Given this list of marker genes Psg27, Musk, Slamf7, Klrc1, Ada, Itga5, Prss8, Ly6g, Cd200r3, Pdcd1lg2, Tnfrsf22, Ackr4, Il11ra1, Dnai2, Fcgrt, Gp2, Itga2b, Cd274, Cd27, Btnl4, Mr1, Cd48, Gypa, Ermap (NCBI Gene Id 99987), Dag1, Scnn1b, Cd4, Raet1e, Chrna4, Ly6g6d, H2-M9, Il21r, Tnfrsf13c, Clec2h, Cd8b1, Skint1, Enpp3, Csf2rb, H2-Eb1, Fcrl5, S1pr1, Adam20, Hfe, Bmpr1a, Clec4d, Asgr2, Tmem123, Ace, Itgal (integrin alpha L), Ccr7, Plau, Ccr6, Cxcr1, Ackr3, Ctla4, Trgc2, Ptprc, Cd33, Asgr1, F2 (coagulation factor II), Ncam1, Ceacam12, Ctsl, Cd276, Skint11, Gfra1, Mpl, Ide, Itga3, H2-T15, Vpreb1a, Trpv1 (transient receptor potential cation channel, subfamily V, member 1), Fgb, Pdcd1, Kit, H2-T13, Tnfsf13, Clec4f, Muc17, Tas2r118 (NCBI Gene Id 387347), Folr1, Il1r1, Btnl1, Ly6c1, Clec10a, Cxcl12, Ccr2 (C-C motif chemokine receptor 2), Abca1 (ATP-binding cassette, sub-family A member 1), Ceacam13, Trdc, Btnl9, P4hb, Crlf2, Ano1, H60c, Vsir, Ly6g5b, Ccr1, Rtn4r, Trpm8, Clec7a, P2rx7, Itga4, Tnfrsf18, Tnfrsf4, Krt18, Ccr1l1, Clec2i, Trgc1, Cfh, Plg, Cd3e, Scube1, Il7r, Adam39, Thbs1, Il4, Itgax, Flt3, Cd83, Klrd1, Ccr5, Cd209c, Siglece, Ctsk, H60b, Il9r, Ccrl2, Gpc4, Fcer2a, Scnn1a, Adam1a, Cd163, Itgb3, Heg1, Htr2c, Icosl, Cd24a, H2-M1, Ece1, Art2b, Tcn2, Ighm, Cd84, Nt5e, Adam6b, Adam34, Map3k5, Cd200r1, Ackr2, Klri1, H2-K1, H2-Aa, Hyal5, Abcb1b, H2-Q1, Ccr4, Itga10, Itgb1, Cd74, Crlf1, Clptm1, Spam1, Cd59b, Enox1, Cxcr5, Adam1b, Trgv2, Ulbp1, Ighd, Car4, 2410137M14Rik, Alpi, Glrb, Skint4 (NCBI Gene Id 320640), Psg25, Fcrl2, Il13ra2, Spa17, Abcc4, Antxr1, Art2a, Clec4a4, Cd86, Slc1a1, Tfrc, Ngfr, Ctsb, Plppr4, Sema7a, Psg26, Lepr, Sell, Fcgr2b (NCBI Gene Id 98391), H2-M5, Abcg2, Il2rg, Mill2, H2-M2, H2-M10.4, Klra4, H2-Q6 (NCBI Gene Id 636948), Vtcn1, Osmr, H2-D1, Klrc2, Gm4787, Cd248, Eng, Tnfrsf14, Tlr8, Itga1, Nlgn1, Astn1, Cd200r2, Itga9, Trgv3, Btn1a1, Chrnb2, Gfra3, Azgp1, Itgam, Itga2, Adam29, H2-M11 (NCBI Gene Id 224754), B4galt1, Skint3, Cxcl10, Gp1ba, Ceacam3, Sele, Robo4, Ccr3, Clec2f, Cxcr6, Anxa5, Lrp2, Cd9, Skint10, Ly6g6c, Btnl2, Adam19, Atp1b2, Kcnj3, Cd44, Mfge8, Plaur, Skint9, H2-T24, Folr2, Adam26a, Vcam1, Rtn4rl2, Cntfr, Cd209a, Clec12b, Adgra3, Slamf6, Cd22, Skint5, Akp3, Il12rb1, H2-Ab1, Adam9, Icam1, Adam21, Flot1, Ccr9, Ccl21b, Klrk1, Fcer1a, Arsa, Itgae, Cr2, Ccr8, Scart2, Adgre1, Cxcr3, Cr1l, Adam26b, Agap2, Il6 (interleukin 6), Itgav, Tnfrsf9, Slc2a4, H2-T22, Cd209e, Skint6, Cd5, Gfra4, Klre1, Clec14a, Clcn3, Cxcr2, Psg16, Prnd, Cd1d2, Btnl10, Cd1d1, Cd40, Slc4a3, Kcnma1, H2-M10.6, Xcr1, Ceacam5, Cd80, Clec2e, Tnfrsf11a, Cd55, Lilrb4a, Tlr4, Lrrc24, H2-M10.1, Slamf1, Vwf, Il17a, Mcam, Scnn1g (sodium channel, nonvoltage-gated 1 gamma), Ceacam15, H2-Ea, Klrb1b, Entpd1, Psg23, Tmc1, Lifr, Ms4a1, Glra1, Ly6g5c, Ccr10, Stab2, H2-M10.5, Tgfbr2, Il31ra, Cd209f, Tnfrsf23, Klra7, Rnpep, Skint2 (selection and upkeep of intraepithelial T cells 2), Calr, Clec4a3, Il11ra2 (NCBI Gene Id 16158), Atp6ap2, H2-M3, Btn2a2, H2-Q2 (histocompatibility 2, Q region locus 2), Fcmr, Prlr, Il12rb2, Clec2d, Alcam, Ceacam1, Itga8, Itgb6, Csf3r (colony stimulating factor 3 receptor), Fcrlb, Cd226 (CD226 antigen), Slamf9, Il1rl1, Cd209b, Il4ra, Ly75, Klrc3, Ceacam14, Igsf21, Cd244a, Tgfbr3, Cd2, Plet1, Il6st, Itgad, Icos, Btnl6, Ceacam11, Adam6a, H2-M10.3, Ceacam23 (NCBI Gene Id 381852), Cd40lg, Prn, Cx3cr1, Slc38a1, Il6ra, Gfra2, H2-T3, Tnf, Rorc (NCBI Gene Id 19885), Cd8a, Pecam1, Psg17, H2-Eb2, Fcgr4, L1cam, Efna5, Cd209g, H2-Q7, Fgg, Selp, Gpihbp1, B2m, Clec4e, Skint7, Capn2, Ghr, Rtbdn, Lct, Cd3d, Clec4b1, Muc16, Trgc4, Fcer1g, Il13, Cd14, Klra1, Itga6, Tlr2, Skint8, Slc7a5, Mill1, Cd69, Ly6a, Cd207, Il2rb, Klrb1c, Mgl2, Adam30 (a disintegrin and metallopeptidase domain 30), Il2ra, Gfral, Fga, Aqp4, Adgre5, Ccl19, Apoe, Izumo1r, Trgv5, Fcrl6, St14, Ly9 (lymphocyte antigen 9), H2-Q4, Raet1d, Abcg1, Fcgr1, Enox2, Cdh5, Psg28, Ms4a2, Gria1, Kdr, Clec4b2, Serpina5, Fcrla, Cd34, Fcgr3, H2-Q10, Csf2rb2 (NCBI Gene Id 12984), Cxcl9, H2-T23, Adam4, Cd79a, Trgv1, H2-T5, Pdpn, Epha5, Insr, Neu3, Cd19, Spn, Iglc1, Cd79b, Psg19, Pirb, Sdc1 (NCBI Gene Id 20969), Tfr2, Cd59a, Clec4a1, Lamp1, P2rx1, Clec4g (C-type lectin domain family 4, member g), Dlk1, Tnfrsf13b, Rs1 (retinoschisis (X-linked, juvenile) 1 (human)), Itgb2, Ighg1, Fgf8, Fasl, Gsr, Cd28, Clec4n, Klri2, Adam34l, Lrp1, Pdgfra, Cxcr4, Adam25, Amot, Thbd, Gucy2g, Btla, Clec4a2, Btnl12, Itga11, Adam24, Kcnj5, Hyal2, Thy1, Fas, Antxr2, Il5ra, Il13ra1, Cdh13, Umodl1, Mog, Anpep, P2ry12, Itga7, Psg21, Clec2g, Lag3, Flt3l (FMS-like tyrosine kinase 3 ligand), H2-M10.2, Lgals3, Chrna7, Il23r, Cd36, Cd3g, Epor, Cd200r4, Enpep, Ifng, Ldlr, 6030468B19Rik, Cd209d, here is a description of the gene set: studied in species Mus musculus The leaflet of the plasma membrane that faces away from the cytoplasm and any proteins embedded or anchored in it or attached to its surface. Mouse Gene Set: GOCC_EXTERNAL_SIDE_OF_PLASMA_MEMBRANE